The following is a description of a gene set: from publication Ongusaha PP, Ouchi T, Kim KT, Nytko E, Kwak JC, Duda RB, Deng CX, Lee SW (PMID 12802282) The tumor suppressor protein BRCA1 has been shown to enhance p53 transcription, whereas activated p53 represses BRCA1 transcription. To further understand the functional interaction of these proteins, we investigated the role of BRCA1 in p53-induced phenotypes. We found that BRCA1 when subjected to forced expression acts synergistically with wild-type p53, resulting in irreversible growth arrest, as shown by VhD mouse fibroblast cells expressing a temperature-sensitive mutant of p53. Furthermore, reintroduction of both BRCA1 and p53 into BRCA1(-/-)/p53(-/-) mouse embryonic fibroblasts markedly increased the senescence phenotype compared to that induced by p53 alone. In particular, we found that BRCA1 expression attenuated p53-mediated cell death in response to gamma-irradiation. Moreover, microarray screening of 11 000 murine genes demonstrated that a set of genes upregulated by p53 is enhanced by coexpression of BRCA1 and p53, suggesting that BRCA1 and p53 exert a promoter selectivity leading to a specific phenotype. Taken together, our results provide evidence that BRCA1 is involved in p53-mediated growth suppression rather than apoptosis. Genes up-regulated in MEF cells (embryonic fibroblast) lacking TP53 and BRCA1 by expression of TP53; most genes are further up-regulated by simultaneous expression of BRCA1. Human Gene Set: ONGUSAHA_TP53_TARGETS species: Mus musculus, and this is the list of marker genes: IVL, TAP1, CTSH, CCNG1, FXYD3, TOB1, SERPINE2, SAT1, PTPRVP, ROBO1, COL18A1, CDKN1A (cyclin dependent kinase inhibitor 1A), AK1, ENPP2, DGKA, CSRP2, SLC66A3, NQO1, EFS, PLTP, CTSF, DAXX, LPIN1, PITPNC1, TP53, MDM2, APOBEC1 (apolipoprotein B mRNA editing enzyme catalytic subunit 1), ANXA8L1, FAS, TNFRSF18, PHLDA3, SRXN1, EPHX1, ERCC5 (ERCC excision repair 5, endonuclease), ZMAT3, COX6B2, MATN4, DDIT4